The following is a description of a gene set: Human Gene Set: GOBP_ESTABLISHMENT_OF_PLANAR_POLARITY_OF_EMBRYONIC_EPITHELIUM species: Homo sapiens Coordinated organization of groups of cells in the plane of an embryonic epithelium, such that they all orient to similar coordinates., and this is the list of marker genes: CELSR1, FOXF2, SEC24B, PAFAH1B1, CTHRC1 (NCBI Gene Id 115908), VANGL2